Given this list of marker genes Twf2, Lima1, Pknox2, Prkce, Pfn1, Myl4, Myl2, Tmsb15a, Tmsb15b1, Mtss2, Pfn4, Cobll1, Tmsb10, Tmsb15l, Mrtfa, Mtss1, Myl3, Abitram (actin binding transcription modulator), Nos3 (NCBI Gene Id 71933), Twf1, Lmod2, Tmsb15b2, Lmod3, Tmsb4x (NCBI Gene Id 19241), Cobl (cordon-bleu WH2 repeat), Coro1a, Pfn2, here is a description of the gene set: Mouse Gene Set: GOMF_ACTIN_MONOMER_BINDING studied in species Mus musculus Binding to monomeric actin, also known as G-actin.